The following is a description of a gene set: Mouse Gene Set: GOBP_OTOLITH_DEVELOPMENT species: Mus musculus The process whose specific outcome is the progression of the otolith over time, from its formation to the mature structure., and this is the list of marker genes: Slc44a4, Oc90, Atg5, Lrig1, Otol1 (otolin 1), Atg4b, Ttc39c, Nox3, Bloc1s5, Atp2b2, Lrig3